The following is a description of a gene set: Human Gene Set: HP_BROAD_FINGER Increased width of a non-thumb digit of the hand. Broad finger species: Homo sapiens, and this is the list of marker genes: RAB23, CASK (NCBI Gene Id 8573), KCNA1, EXOSC2, EXTL3, GNAS, FBN1, G6PC3, SIAH1, CHST3, PRKG2, GPC4, SLC32A1, SATB2, IFIH1, PIGQ, CBFB, RPS6KA3, B3GALT6, DHX30, COL10A1, SMOC1, TBCK, ACAN, HS2ST1, PYCR2, CDC42BPB, SLC25A22, SETD5, ALX4 (ALX homeobox 4), PNKP, FBXO11, DVL1, FGFR1, CTNNB1, ARHGEF2, IFT122, AMMECR1, B3GAT3, WNT5A, IFT56, PSMD12, RTL1, GLI3, MAP3K7, SIK1, BGN, ZNF668, NHS, BMP2, XYLT1, GJA5, SNIP1, H3-3B, GRIN1, DACT1, TRPM3, SCN2A, H3-3A, HPGD, GDF5, PRKD1, CDKL5, INPPL1, NOG (noggin), GJA8, FLNB, MAN2C1, SUMF1, FGFR2, ROR2, PUF60, MEGF8, DMXL2, SUZ12, MEG3, CREBBP, SRCAP, PIGP, GATA4, GPC3, SALL1, KIF22, LMBR1, EP300, USP9X, NPR2, KCNH1, HOXD13, GRM7, KNSTRN, RERE, KCTD1, RNU4ATAC, LIG4, PCDHGC4, DVL3, ADNP, TWIST1, FLNA, NXN, FGFR3, EED, MEIS2, OFD1, BPTF, OTUD6B, DNM1L, SMO, BMPR1A, PIK3CD, WDR19, WLS, ZNF141, NSD1, TRIM8, GATAD2B, DLK1, SCN1B, TBX5, NEUROD2, EZH2, MSX2, COL2A1, GNAO1, SMARCA2, PTEN, HNRNPR, POGZ, ARX, RLIM, RBM8A, NEPRO, MED12, ADAMTS10, PACS1, NSUN2, FGF9, BICRA